The following is a description of a gene set: species: Homo sapiens DNA Repair Human Gene Set: REACTOME_DNA_REPAIR, and this is the list of marker genes: POLD1, FANCD2, TERF2, H4C9, XPA, NSD2, WDR48, GEN1, PRKDC, PPP4C, H2AX, MNAT1, POLR2F, XRCC1, RFC5, RIF1 (NCBI Gene Id 55183), H4C1, POLR2E, UBE2I, VCP, POLN, H4C4, RAD23B, H4C14, POLR2K, XPC, FEN1, ALKBH3, RAD51D, KPNA2, HUS1, ALKBH5, BABAM1, POLK, H2AC7, COPS8, ERCC4, INO80, CUL4A, RAD51B (RAD51 paralog B), MUTYH, APBB1 (NCBI Gene Id 322), PARP2, UBE2B, REV1, EYA2, PCLAF, GTF2H5, RAD9A, DDB2, COPS5, H4C5 (NCBI Gene Id 8367), MAPK8, POLR2G, DNA2, POLL, EYA4, EME2, POLR2I (RNA polymerase II subunit I), UIMC1, PCNA, FANCF, H2BC26, FANCC, BRCC3, ERCC3, NEIL2, RPA3, ACTR5, UBE2T, RFC1, FANCL, SEM1 (SEM1 26S proteasome subunit), ADPRS, CHD1L, ATM, RFC3 (replication factor C subunit 3), TERF2IP, PALB2, H2BC8, POLD2, PPP5C, BRIP1, COPS6, TOP3A, POLI, RAD23A (RAD23 homolog A, nucleotide excision repair protein), FANCI, MAD2L2, TIPIN, TCEA1, H2AB1, CCNH, UBC, ALKBH2, TIMELESS, EME1, POLE2, H2BC5, REV3L, EYA1, MPG, ASCC1, UBE2V2, RAD51, H2BC10, INO80E, NFRKB, CHEK1, ERCC8, ASCC3, INO80C, SPIDR, H2AC20, POLB, GTF2H4, GPS1, H2AJ, H4C16, TRIM25, H4C12, ERCC6, H2BC15, ACTL6A, H2BC9, H2BC7, NEIL3, SLX1A, H2AC19, UBA52, RTEL1, POLR2C, POLR2J, RAD18, DDB1 (damage specific DNA binding protein 1), COPS7A (NCBI Gene Id 50813), TP53BP1, UBE2N, H2BC1, H4C2, MCRS1, UVSSA, RCHY1, UBE2L6, PIAS1, ELL, RBX1, GTF2H3, PPP4R2 (protein phosphatase 4 regulatory subunit 2), APEX1, ISY1, AQR (NCBI Gene Id 9716), CETN2, POLE (NCBI Gene Id 80252), RFC4, SUMO1, UBA7 (ubiquitin like modifier activating enzyme 7), CUL4B, NEIL1, NHEJ1, RPA2 (replication protein A2), PIAS3, H2AZ2, RNF8, CDK7, XRCC6, ISG15, RUVBL1, LIG4, UBB, H2AC8, H4C15, LIG1, OGG1, RPA1, MRE11, BABAM2, POLE3, BRCA1, POLE4, H2AC4, H2BC12, FAN1, CCNA1, MGMT, H2BC6, BARD1, CCNA2, POLQ, POLR2B, RAD52, FAAP24, H3-4, MSH2, FTO, BAZ1B, RBBP8, UBXN1, MSH6, FIRRM, NPLOC4, XRCC5, POLD3, TDP1, PARP1, PRPF19, H4C11, YY1, INO80D, POLR2D, ATRIP, POLR2A, RAD51C (NCBI Gene Id 5889), BLM, MBD4, RPS27A, CHEK2, COPS2, POLH, POT1, H4C6, ACD, SLX4, ATR, GTF2H1, SMARCA5, UFD1, SUMO2, DCLRE1C (NCBI Gene Id 64421), H2BC14, INO80B, DCLRE1A, PAXIP1, RAD50, ZNF830, USP1, USP43, RNF111, ASCC2, TDP2, H2BC3, XAB2, RAD1, COPS4, H2AC6 (H2A clustered histone 6, NCBI Gene Id 8334), SIRT6, FIGNL1, UNG (uracil DNA glycosylase), H2BC21, TOPBP1, FANCG, PMS2, MDC1 (mediator of DNA damage checkpoint 1), H2AC18, FAAP100, SMUG1, TINF2, COPS7B, ACTR8, RNF168, KAT5, FAAP20, RAD51AP1, SPRTN, PIAS4, PPIE, USP7, WRN, CENPX, MSH3, XRCC4, NTHL1, FANCB, H2BC4, MUS81, H4C8, FANCA, COPS3, LIG3, H2AC14, RFC2, RMI1, PARG, POLD4 (DNA polymerase delta 4, accessory subunit), FANCE, BRCA2, BAP1, PNKP, ABRAXAS1, KDM4A, H2BC17, DTL (denticleless E3 ubiquitin protein ligase homolog), H4C13, XRCC3, POLR2L, POLM, RMI2, RNF4, ERCC1, H2BC11, ERCC5, MLH1, TFPT, TERF1, EYA3, USP45, ACTB, USP10, H2BC12L, DCLRE1B, EXO1, ABL1, SUMO3, SLX1B, H4C3, RAD17, CDK2, H2BC13, CLSPN, RAD9B, TDG, GTF2H2, CENPS, RHNO1, KDM4B, TP53, POLR2H, ERCC2, FANCM, NBN, XRCC2, HERC2